The following is a description of a gene set: Mouse Gene Set: GOMF_HYDROLASE_ACTIVITY_ACTING_ON_ESTER_BONDS studied in species Mus musculus Catalysis of the hydrolysis of any ester bond., and this is the list of marker genes: Acot3, Pld3, Ces1b, Car1, Polrmt, Rad9a, Plcl2, Dusp15, Hsp90b1, Adprs, Ercc4 (NCBI Gene Id 50505), Ptpn3, Uri1, Mrpl58, Ppp6r2, Zc3h12a, Ptprb, Baat, Rnasel, Angptl3, Ercc1, Slfn1, Dusp6 (NCBI Gene Id 67603), Ppp2r1a, Pde8a, Tulp2, Pla2g15, Ppp4r2, Dusp29, Pde3a, Ang5, Ptpn20, Gpihbp1 (NCBI Gene Id 68453), Pde10a, Plcl1, Ago4, Ago2, Inpp1, Abhd3, Ear1, Sgpp1, Dusp1, Ces2h, Dusp16, Cnep1r1, Lpin2, Myoz1, Pnpla6, Ppp2r5b, Usb1, Pld4, Ppp2r5c, Ern1, Lipo2, Cdc25c, Abhd17c, Ptprg, Ppp1r9b, Galns, Plppr3, Ssh2, Ppm1g, Aptx, Dna2, Abhd13, Eri1, Plpp1, Abcd2, Ptprh, Apoc2 (apolipoprotein C2, NCBI Gene Id 11813), Rnase2a, Apoa2, Ptpdc1, Acp2 (acid phosphatase 2, lysosomal), Ppp1r15a, Pla2g4a, Atp1a1, Ppp1r1a, Rbbp8, Inpp5f, Ppp2r3a, Dclre1c, G6pc2, Dclre1b, Adprm, Pon1, Ppm1a, Dnase1l1, Cabin1, Nt5dc3, Aoah, Sgpp2, Ppm1f, Arf1, Ppp1ccb, Phospho1, Pla2g4d, Rnase2b, Gnaq, Ptp4a1, Rpp30, Ptpn9, Bivm, Pla2g10, Ssh1, Pld6, Pfkfb3, Pde4d, Polg (NCBI Gene Id 208850), Ppp2r5a, Abhd2, B3gat3, Ppp1r14a, Lipg, Gdpd3 (glycerophosphodiester phosphodiesterase domain containing 3), Pgap3, Ctdspl, Trex2, Cpsf3, Abhd1, Sgsh, Alkbh3, Acot1, Cd33, Ppp6c, Ces1d, Plaa, Rida, Ppm1l (protein phosphatase 1 (formerly 2C)-like), H6pd (hexose-6-phosphate dehydrogenase (glucose 1-dehydrogenase)), Rexo4, Ptpn18, Aen, Ces2f, Dnase1, Mtmr14, Slfn4, Exosc10, Tigar, Lpl, Desi1, Rnase1, Ptprv, Acot4, Inpp5j (NCBI Gene Id 170835), Ces2g, Mtmr10, Ptpn12, Inpp4a, Ndst2, Siae, Rpe65, Alpi, Pde7b, Calm1, Xrcc4, Tiprl, Ppp4r3c1, Ptpn11, Ppp1r14b, Ces2a, Dnase2b, Plcd4, Ern2, Styxl1, Gdpd1, Cln5, Pde3b, Ptpn1, Synj1, Ptpru, Gde1, Smpd3, Fbp1, Sacm1l, Pop1, Acsbg2, Mtmr11, Cdc14b, Pde9a, Pnpla2, Acot7, Tns3, Pde11a, Pla1a, Pde6h, Dnase1l3, Plpp6, Faah, Desi2, Ctdspl2, Ctdsp1, Gen1, Apoc3, Pip4p1, Slx1b, Ppp1r1c, Pon2, Pank4, Eya3, Gpld1, Mtmr4, Cnp, Napepld, Acot11, Plaat3, Pld5, Alppl2, Ppp4r1, Ang4, Arl1 (ADP-ribosylation factor-like 1), Rexo1, Bod1, Ppm1n, Anp32e, Pfkfb2 (NCBI Gene Id 75925), Wbp11, Exd1, Nit1, Pabir2, Ppp1cc, Dxo, Piwil1, Plpp2, Ptprn2, Rad51c, Tesc, Ankzf1, Bmp2k, Dusp5, Ppp2ca, Plscr2, Eri3, Abhd8, Ppp2r5e, Rcan1, Dmpk, Dusp14, Fra10ac1, Dnase1l2, Plcb3, Ppp3ca, Pla2g4c, Scgb1a1, Rexo2, Lpin3, Dusp28, Acot13, Nt5m, Rpp25, Pla2g5, Car3, Acp6, Dis3, Ptk2, Ces2e, Epm2a, Dffa, Anxa2, Ces2b, Ppp1r14c, Armt1, Dusp11, Pgs1, Ces1h, Nob1, Phactr1, Enpp3, Gtf2f1, Aspa, Iah1, Entpd3, Harbi1, Dis3l2, Ppp2r1b, Plpp3, Acot6, Nt5dc2, G6pc3, Inpp4b, Bckdk, Pde4b, Elfn2, G3bp1, Ppp6r3, Cdca2, Ambra1, Tmem225, Lipf, Daglb, Exo5, Pnpla8, Pinlyp, Xrn2, Aldh2, Pnpla7, Eya1, Abhd6, Hibch, Gns, Ppp6r1, Ppm1e, Ficd, Minpp1, Endou, Phlpp2, Acp4, Pla2g2c, Ces1c, Wrn, Ndst3, Aspg, Abhd5, Plpp4, Rad50, Acp7, Pfkfb4, Tns1, Drosha, Ptpn2, Ephx2, Ppp1r15b, Dtd1, Mgme1, Calm3, Pitpnm3, Lipk, Faf2, Impa2, Ppt1, Mtmr3, Apex2, Enpp1, Anxa1, Rpap2, Mtmr6, Cip2a, Ang, C1qbp, Pla2g12a, Vrk3, Mus81, Nudt16l2, Dusp8, Ankle1, Mtmr12, Ptp4a2, Pxylp1, Pafah1b3, Mdp1, Arsj, Prune1, Tsen2, Nt5c1a, Ppp1r16b, Sulf2, Mtmr1, Enpp7, Rnaseh2a, Pald1, Cdc25a, Ssu72, Pop5, Ppp1r27, Apmap, Dusp22, Lcat, Pop4, Plcxd3, Pld2, Alpl, Pnlip, Cdc25b, Setmar, Hmox1, Eri2, Sts, Pter, Src, Pp2d1, Zc3h12b, Slfn3, Ssh3, Pde1b, Fig4, Ptpn4, Nt5c1b, Inpp5b, Pnliprp1, Pnpla5, Mtmr7, Aste1, Alkbh2, Ear6, Abce1, Pde4a, Pop7, Dph7, Ang6, Ddhd1, Smg6 (SMG6 nonsense mediated mRNA decay factor), Bphl, Tmbim6, Anxa3 (NCBI Gene Id 11745), Ppp1r2, Acot2, Notum, Nsmaf, Ilkap, Pde6b, Ptpn7, Pde1a, Ppp1r37, Smpdl3b, Gm2a, Apoa1, Smpd1, Endov, Arsi, Btk, Exo1, Igbp1b, Plce1, Ppp3r1, Lipa, Sh3rf2, Pde8b, Ptpra, Ache, Abhd11, Ppa2, Ptpro, Slfn8 (schlafen 8), Dcp2, Exd2, Fbp2, Smpd5, Meiob, Plcz1, Ppp3cc (protein phosphatase 3, catalytic subunit, gamma isoform), Ppp2cb, Zc3h12c, Ppp1r3c, Ppp1r12a, Rcan2, Acy3, Lipi, Rcan3, Macrod1, Nme8, Phpt1, Hdhd2, Etf1 (NCBI Gene Id 52117), Eme2, Plcb1, Ptp4a3, Them7, Eme1, Ptprq, Dusp9, Pgp, Plaat1, Acp1, Enoph1, Rgn, Olah, Ppm1m, Snd1, Ppp1r1b (protein phosphatase 1, regulatory inhibitor subunit 1B), Gdpd5, Pde2a, Smpdl3a, Rad1, Fan1, Mrpl44, Ppp2r2c, Rpp14, Rag1, Plppr2, Gdpd4, Acot8, Pdpk1, Bche, Ces2c, Lypla2, Pla2g7, Rnase11, Abhd12b, Cnot7, 2810408A11Rik, Ppp2r2d, Pafah1b2, Hddc3, Zc3h12d, Pdxp, Pde6g, Ppef1, Rpp21, Arsa, Pld1, Rnase12, Pfkfb1 (6-phosphofructo-2-kinase/fructose-2,6-biphosphatase 1), Tsnax, Ptn, Pafah2, Acnat1, Zranb3, Cnot2, Plpp5, Rnasek, Ocrl, Ppme1, Pgbd5, Endog, Hnf4a, Mpped2, Inpp5e, Pde6d, Pde12, Plaat5, Toe1, Sulf1, Aldh6a1, Pla2g4e (NCBI Gene Id 71894), Tsn, Tprn, Pnliprp2, Ptprf, Fancm, Apoh, Ensa, Pnkp, Plpp7, Gm8978 (predicted gene 8978), Ces1e, Ubash3b, Dclre1a (NCBI Gene Id 80616), Arhgap6, Ptbp1, Gnb1, Acaa2, Pde5a (NCBI Gene Id 242202), Prorp, Ppm1h, Ces3b (carboxylesterase 3B), Ppp4r4, Polq, Pms2, Dusp18 (dual specificity phosphatase 18), Ppp1r10, Ptpn21, Dusp19, Ppp2r3d, Ctdnep1, Las1l, Abcd1, Nme5, Mgat5, Gdpd2, Trex1, Dusp13b, Pde4c, Hras, Tdp1, Ccl5, Lipo4, Abcd3, Nme1, Inpp5k, Ppm1d, Gm28729, Lhpp, Rnh1, Gna11, Nudt16l1, Ptprk, Haghl, Sirpa (NCBI Gene Id 99074), Chka, Pnpt1, Plppr5, Abhd16a, Mre11a, Plcxd2 (phosphatidylinositol-specific phospholipase C, X domain containing 2), Ces1f, Ppp1r36, Ppp1r3b, Acp5, Dynll1 (NCBI Gene Id 56455), Ddx1 (DEAD box helicase 1), Them5, Arf4, Ear2, Dusp13a, Ndst1, Ptrh1, Bpnt1, Khnyn (NCBI Gene Id 69626), Ywhab, Prdx6, Noct, Samhd1, Smtnl1, Ppp1r7, Piwil2 (NCBI Gene Id 57746), Nt5c3b, Smpd4, Fasn, Styx, Eya4, Slfn9, Pla2g2f, Sbf1, Ptprm, Nt5dc1, Rnaset2a, Pdgfra, Arsg, Abhd17a, Lactb2, Ctdsp2, Ptrhd1, Pnpla3, Esd-ps, Pabir1, Nanp, Ddhd2, Lipm, Lipc, Nme7, Phospho2, Tatdn3, Ang2, Dtd2, Lpin1, Tns2, Calm2, Gnas, Ppp1r3e, Dusp7, Dffb, Xrn1, Pde6a, Tdp2, Dis3l, Ptpn23, Ces3a, Rnase10, Plcg1, Elac1, Xrcc3, Pgls, Synj2, Pla2g4f, Tsen34, Exosc3, Hagh, Cnot1, Ptprz1, Tab1, Ccl3, Mtm1, Igfbp2, Fen1, Dusp12, Ppp1r14bl, Nt5c3, Ptpn14, Pan2, Rnase6, Ywhae (NCBI Gene Id 22627), Ppp1r3a, Acot9, Pla2g2e, Abhd17b, Slfn2, N4bp1, Apex1, Cmya5, Ear10, Ptpn22, Pole, Tnfaip6, Ptprd, Ints11, Plppr4, Pan3, Dusp23, Cpt1c, Ppp2r2b (protein phosphatase 2, regulatory subunit B, beta), Lipo1, Mblac2, Dnajc6, Isg20, Ppm1k, Pde1c, Pnkd, Cdkn3, Liph, Cpped1, Pgap1, Sec23ip, Hsp90ab1, Ptpn13, Dusp21, Ppp1cb, Pla2g12b, Ercc5, Ppp1r3d, Dbr1, Ppp1r17, Cry2, Plcd3, Macrod2, Rnase9, Apoc2l, Hddc2, Cnot6, Prdx6b, Sbf2, Ptpre, Abhd16b, Dusp10, Ublcp1, Pla2g4b, Acot12, Pon3, Ppp1r12b, Igbp1 (NCBI Gene Id 97609), Rpp40 (NCBI Gene Id 24016), Rcl1, Abhd4, Pgap6, Arsk, Nceh1, Bpnt2, Pde6c, Eed, Akp3, Plch1 (NCBI Gene Id 269437), Pold1, Ppp4r3c2, Phlpp1, Aadacl3, Pla2g1b, Ptprj, Cnot6l (NCBI Gene Id 338514), Apoa5, Abhd10, Ptprt (NCBI Gene Id 19281), Aplf, Rngtt, Ppp3r2, Acp3, Ces5a, Timm50, Inpp5a, Tescl, Myg1, Ptpn6, Ppp2r2a, Ccr1, Ppt2, Ppp1r26, Ptprs, Trir, Pla2g2a, Arsb, Pgam5, Ids, Inppl1, Rexo5, Helz2, Slc39a10, Ctdp1, Inpp5d, Ppp3cb, Pla2g2d, Ppp1r11, Ybey, Htt, Igfbp3, Plbd2, Itga1 (integrin alpha 1), Ccr1l1, Pip4p2, Acot5, Plcxd1, Nudt12, Ppp1r8, Ppp1r35, Phactr3 (phosphatase and actin regulator 3), Ppp4r3a, Parn, Dnase2a, Lck, Ppp1ca, Ppp2r5d, Elfn1, Ppp4c, Pde7a, Ces1g, Cdc14a (CDC14 cell division cycle 14A), Car2, Arpp19, Ptprr, Plbd1, Abhd15 (abhydrolase domain containing 15), Exog, Pdp2, Psph, Ppef2, Fyn, Dusp2, Nt5c2, Isg20l2 (NCBI Gene Id 97085), Plch2, N4bp2, Rnase4, Ptprn, Ldah, Rpp38, Nt5e, Styxl2 (NCBI Gene Id 640366), Enpp6, Ppp1r16a, Tpte, Lmtk2, Pnpla1, Casp3, Esd, Dusp3, Elac2, Rps3, Lypla1, Ces1a, Cwf19l1, Ear14, Lipe, Tatdn1, Ppp1r12c, Dusp4 (dual specificity phosphatase 4), Ptpa, Ptpmt1, Ppp4r3b, Ptrh2, Mblac1, Oard1, Pnldc1, Dagla, Plcg2, Pudp, Cnot8, Mtmr2, Stx4a, Styx-ps, Mgll, Them4, Slfn14, Pla2g3, Pptc7, Impa1, Pla2g6, Proca1, Ccl8, Mppe1, Aadac, Marf1, Nt5c, Alkbh5, Rnaseh1, G6pc1 (glucose-6-phosphatase catalytic subunit 1), Plcb2, Lipn, Bmp2, Acot10, Acnat2, Ppm1b, Gpcpd1, 4931406C07Rik, Smpd2, Apoc1, Piwil4, Dicer1, Oc90, Lipo3, Csnk2a1, Nynrin, Pdp1, Plscr1, Phactr4, Ppp1r14d, Eya2, Endod1, Plcb4, Plb1, Gna12, Cel, Ppm1j, Dusp26 (NCBI Gene Id 66959), Ces4a, Rnase13, Ptpn5, Enpp2, Plppr1, Abhd12, Ptprc, Nudt16, Ppp5c, Lyplal1, Pten, Rnaset2b, Xrcc1, Plcd1, Ago3